The following is a description of a gene set: studied in species Homo sapiens Genes predicted to be targets of miRBase v22 microRNA hsa-miR-4673 in miRDB v6.0 with MirTarget v4 prediction scores > 80 (high confidence targets). Human Gene Set: MIR4673 from publication Chen Y, Wang X (PMID 31504780), and this is the list of marker genes: SDC1, SLC25A32, GPR171, ZSCAN22, UBE2G2, SETD5, IL3, BAGE2, TBC1D2B, MNT, FOXO3, SIX4, PHTF1, DOCK11, PTK7, CDIN1, SRPRA, IGDCC4, PSORS1C1, MRAS, TMPRSS13, SPTSSB, RANBP10, MAF1, VDAC3, TMEM126B, ZHX2, ERG, GTF2H5, SYN1, SMAD4, VTA1, KCTD6, AK2, AIRE, SLAMF8, TMEM208, ARF4, PAPOLG, CCNL2, LRPAP1 (LDL receptor related protein associated protein 1), WASHC4, PDAP1, EREG, CDH22, RBBP6, TLK1, KIF3A, ZSCAN12, GPR12, TEX261, HHLA2, CNTN2, OPRM1, ZBTB14, KCND3 (NCBI Gene Id 3752), MYRF, EGF, WWTR1, FAM107A, PLA2G12B, THOC2, MSANTD1, B4GALT1, UBFD1, CEMIP2, CACFD1, CXXC5, LPIN3, SH3PXD2B, MTCL2, KCNE4, FAM98B, BSPRY, SHC2, DHCR24, CNOT6, RSBN1, MPPED1, BCR, PIM2, TSHR, SRGAP2B, ZMAT2, LMAN2L, HEYL, LSM14A, JADE1, SLC51A, STT3B (STT3 oligosaccharyltransferase complex catalytic subunit B), ENO2, TNK2, ATXN7 (NCBI Gene Id 6314), DVL2, FGFRL1, SOCS1, TSPYL5, KLHL29, SRGAP2C, GCC1, CNNM3, DIO3, SGSH, AP4B1, NEU3, RAPGEF2, NXPH1, ADAM11, SPTSSA, C10orf62, PAQR7 (progestin and adipoQ receptor family member 7), ZNF132, ERP29, SLC15A4, ABR, FBXW4, SPOP, EXD1, SLC5A1, MRTFA, ADA2, LINC02907, GPATCH2L, PDXK, IRGQ, SH3BP2, ACTR1A, DELE1, GPC5, SERTAD4, CHMP7, SLC35B4, FBXO45, GLDC, ARHGAP36, GBX2, TRIL, NDST1, ATP11C, BACE1, KY, NCLN, TRIM36, PLA2G3, NSL1, BICD2, PHF21A, FERMT2, KSR2